Given this list of marker genes Cyp1b1, Rdh12, Cyp1a2, Lipe, Rdh13, Ces2a, Awat2, Rbp4, Plb1, Aldh1a1 (NCBI Gene Id 320092), Ces1d, Adh1, Rdh11, Dgat1, Rdh19, Rbp1, Rdh14, Rdh10, Lrat, Rdh1, Dhrs4, Rdh16, Rdh8, Aldh1a3, Pnlip, Rdh7, Adh6b, Akr1b1, Retsat, Dgat2, Ces2e, Adh4, Rdh16f2, Sdr16c5, Dhrs3, Rdh9, Rpe65, Ces1f, Hsd17b6 (hydroxysteroid (17-beta) dehydrogenase 6), Dhrs7, Adh6a, Aldh1a2, Cyp1a1, Ces1e, Adh7, Ces2c, Sdr9c7 (4short chain dehydrogenase/reductase family 9C, member 7), Rdh5 (retinol dehydrogenase 5), Pnpla2, Bco1, here is a description of the gene set: The chemical reactions and pathways involving retinol, one of the three compounds that makes up vitamin A. studied in species Mus musculus Mouse Gene Set: GOBP_RETINOL_METABOLIC_PROCESS